Given this list of marker genes Phf24, Tmc2, Tmc1, Pcdh15, Trpa1, Grin2a, Itga2, Htr2a, Igf1, Col11a1 (NCBI Gene Id 77655), Piezo2, Mkks, Tmem87a, Strc, Ntrk1, Cxcl12, Tlr4, Whrn, Adgrv1, Scn1a, Bace1, Tmem120a, Fyn, Kcnq1, Asic3, Htr7, Chrna10, Rest, Scn11a, Chrna5 (cholinergic receptor, nicotinic, alpha polypeptide 5), Scn10a, Pawr, Hpn, Il18, Serpine2, Atp2b2, Myc, Kcnk2, Tnf, Grin2d, Scn9a, Pjvk (pejvakin), Slc12a2, Lhfpl5, Asic2, Chrna9, Kit, Ptprq, Grin2b, Kcna1, Pdzd7, Sox2, Cxcr4, Kcnk4, Ano1, Grm8 (glutamate receptor, metabotropic 8), Cacnb3, here is a description of the gene set: Mouse Gene Set: GOBP_DETECTION_OF_MECHANICAL_STIMULUS_INVOLVED_IN_SENSORY_PERCEPTION species: Mus musculus The series of events in which a mechanical stimulus is received and converted into a molecular signal as part of sensory perception.